The following is a description of a gene set: The clustering together and adhesion of initially separate cells to form an aggregate. Examples include the clustering of unicellular organisms or blood cells in suspension and the condensation of mesenchymal cells during cartilage formation. studied in species Homo sapiens Human Gene Set: GOBP_CELL_AGGREGATION, and this is the list of marker genes: CCN2, MYCN, BMPR1B, FGF6, COL11A1, BPIFA1, MAPK14, MPZ, LTF, WNT7A (NCBI Gene Id 7476), SOX9, PKD1, FGF4, SOX5, TMIGD1, THRA, TGFB2, COL2A1, BARX2, OTOR, UNCX, BMP1, MGP, SOX6, MYF5